The following is a description of a gene set: Mouse Gene Set: GOBP_FATTY_ACID_DERIVATIVE_BIOSYNTHETIC_PROCESS species: Mus musculus The chemical reactions and pathways resulting in the formation of fatty acid derivative., and this is the list of marker genes: Acaa1b, Alox5, Elovl3, Pam, Scp2, Abcd1, Slc27a5, Elovl2, Acaa1a, Elovl5, Acox1, Far2, Far1, Alox8, Ggt5, Acsl5, Tmem135, Abcd2, Elovl1, Awat2, Acat1, Hmgcl, Acsl4, Elovl7, Acsl1, Acot8, Hsd17b4, Alox12, Acsl6, Elovl6, Hmgcll1, Hmgcs2, Ehhadh, Gcdh, Fads1, Elovl4, Fads2, Alox15